The following is a description of a gene set: Binding to a small regulatory RNA, a short RNA (usually 50-200 nt long) that is either independently transcribed or processed from a longer RNA by an RNAse enzyme. species: Mus musculus Mouse Gene Set: GOMF_REGULATORY_RNA_BINDING, and this is the list of marker genes: Tex19.2, Piwil2, Rbm4 (RNA binding motif protein 4), Dicer1, Rbm10, Pnpt1, Spout1, Fmr1, Cnot7, Ago3, ENSMUSG00000126352, Arb2a, Ago4, Ago2, Dhx9, Sox2, Lin28a, Mbd2, Zc3h10, Piwil4, Qki, Piwil1, Hnrnpu, Tarbp2, Tlr9, Zc3h7b, Hnrnpa1, Pou5f1, Pum2 (pumilio RNA-binding family member 2), Fgfr3, Mir484, Rc3h1, Hnrnpa2b1, Ddx21, Tex19.1, Gm15290, Socs3, Ago1, Tut4, Zc3h7a, 2810429I04Rik, Mecp2, Elavl1, Tlr7, Ybx1, Prkra, Trim71 (NCBI Gene Id 72491), Tut7, Zc3h12a, Zfp346, Sox4, Mir361 (NCBI Gene Id 723850), Pum1, Mov10l1, Dnd1, Kcnq1ot1, Matr3